The following is a description of a gene set: Mouse Gene Set: REACTOME_IL_6_TYPE_CYTOKINE_RECEPTOR_LIGAND_INTERACTIONS IL-6-type cytokine receptor ligand interactions species: Mus musculus, and this is the list of marker genes: Osmr, Jak2, Il31ra, Il11 (interleukin 11), Lifr, Lif, Cntfr, Il31, Clcf1, Crlf1, Tyk2, Il11ra1, Cntf, Il6st, Ctf1, Osm